Given this list of marker genes MUC16, MEGF8, EMID1, CLEC11A, SVEP1, CSPG4, P3H1, ADAM9, FGL2, PAPLN, PLOD1 (NCBI Gene Id 5351), EFEMP2, LEFTY1, TGFB1, FMOD, AGRN, SERPINB1, PLOD2, LTBP2, ST14, S100A16, LOXL2, PXDN, PLXND1, SERPINF1, MXRA5, SERPINE2, FCN1, SFTPD, S100A14, TIMP1, C1QA, MMP2, MMP12, MMP1, PLXNB2, F2, THBS2, ADAM10, GPC4, ADAMTSL1, MUC13, SPARC, HTRA1, PLOD3, SERPINA3, C1QB, ANXA5, HMCN1, INTS14, MMRN2 (NCBI Gene Id 79812), MMRN1, COL22A1, MMP9, S100A11, HCFC1, MMP11, MFGE8, LOXL1, here is a description of the gene set: species: Homo sapiens Matrisome proteins found differentially expressed in primary metastatic colon tumors in comparison to normal colon and normal liver. In order to identify candidate biomarkers, we sought to define ECM signatures of metastatic colorectal cancers and their metastases to the liver. We obtained patient-matched metastatic colorectal cancer samples (primary tumor and paired metastases to liver) and normal colonic tissue from three patients from Massachusetts General Hospital s tissue bank. We also obtained normal liver tissue from healthy donors. We have used enrichment of ECM from human patient samples and proteomics to define the ECM composition of primary colon carcinomas and their metastases to liver in comparison with normal colon and liver samples. We defined, for each tissue or tumor type, its matrisome as the ensemble of proteins detected in at least two of the three patients studied. Based on these changes, we derived ECM protein signatures of primary colon carcinoma and primary colon tumor metastasis to liver. Comparisons of these signatures with available clinical gene expression array data show that subsets of these signatures correlate well with tumor progression and metastasis. Importantly, we identified subsets of tumor-specific proteins either characteristic of the colon tumor matrisome or characteristic of the metastasis matrisome. This gene set lists the matrisome proteins detected either exclusively or in significantly higher abundance in primary metastatic colon tumors compared to normal colon and liver. from publication Naba A, Clauser KR, Whittaker CA, Carr SA, Tanabe KK, Hynes RO (PMID 25037231) Human Gene Set: NABA_MATRISOME_PRIMARY_METASTATIC_COLORECTAL_TUMOR